The following is a description of a gene set: studied in species Homo sapiens Human Gene Set: GOCC_ASYMMETRIC_GLUTAMATERGIC_EXCITATORY_SYNAPSE A neuron to neuron synapse with a postsynaptic density, that uses glutamate as a neurotransmitter and whose activity results in excitatory postsynaptic potentials., and this is the list of marker genes: NLGN4X, SHISA6 (shisa family member 6), GRID2IP, PLXNA4, SHISA7, NLGN4Y, NLGN3, PLXNC1, ADGRB3, C1QL1, C1QL2, NLGN1, ITGB1, CHD4, GRN, TMEM240, SORT1, YWHAH